The following is a description of a gene set: Human Gene Set: GOBP_GTP_BIOSYNTHETIC_PROCESS The chemical reactions and pathways resulting in the formation of GTP, guanosine triphosphate. species: Homo sapiens, and this is the list of marker genes: NME6, NME2P1, NME3, IMPDH2, IMPDH1, NME2, NME1 (NCBI Gene Id 7794), NME4, NME9, NME7, NME5